Given this list of marker genes HSPA5, SNCA, EIF2S1, DDIT3, ATF4, EIF2AK3, here is a description of the gene set: species: Homo sapiens Pathway Definition from KEGG: SNCA* -| BIP -| EIF2AK3 -> EIF2S1 -> ATF4 => DDIT3 Mutation-caused aberrant SNCA to PERK-ATF4 signaling pathway. Pathway ID: N01035. Pathway type: Variant. Pathway class: nt06534 Unfolded protein response. Human Gene Set: KEGG_MEDICUS_VARIANT_MUTATION_CAUSED_ABERRANT_SNCA_TO_PERK_ATF4_SIGNALING_PATHWAY